The following is a description of a gene set: part of: Metabolism Reactome Pathway: Metabolism of porphyrins Porphyrins are heterocyclic macrocycles, consisting of four pyrrole subunits (tetrapyrrole) linked by four methine (=CH-) bridges. The extensive conjugated porphyrin macrocycle is chromatic and the name itself, <b>porphyrin</b>, is derived from the Greek word for <i>purple</i>. The aromatic character of porphyrins can be seen by NMR spectroscopy.<br>Porphyrins readily combine with metals by coordinating them in the central cavity. Iron (heme) and magnesium (chlorophyll) are two well known examples although zinc, copper, nickel and cobalt form other known metal-containing phorphyrins. A porphyrin which has no metal in the cavity is called a <i>free base</i>.<br>Some iron-containing porphyrins are called hemes (heme-containing proteins or hemoproteins) and these are found extensively in nature ie. hemoglobin. Hemoglobin is quantitatively the most important hemoprotein. The hemoglobin iron is the transfer site of oxygen and carries it in the blood all round the body for cell respiration. Other examples are cytochromes present in mitochondria and endoplasmic reticulum which takes part in electron transfer events, catalase and peroxidase whic protect the body against the oxidant hydrogen peroxide and tryptophan oxygenase which is present in intermediary metabolism. Hemoproteins are synthesized in all mammalian cells and the major sites are erythropoietic tissue and the liver.<p>The processes by which heme is synthesized, transported, and metabolized are a critical part of human iron metabolism; here the core processes of heme biosynthesis and catabolism have been annotated. studied in species Homo sapiens, and this is the list of marker genes: BLVRA, ABCC1, PPOX, HMOX2, COX10, UGT1A4 (NCBI Gene Id 54657), UGT1A1, FABP1, GUSB, SLCO2B1, ABCC2, UROS, SLCO1B1, UROD, ALAS1, BLVRB, SLCO1B3, HMBS, ABCG2, COX15, CPOX, ALAS2, GSTA1 (glutathione S-transferase alpha 1), FLVCR1, FECH, ALB, ALAD, HMOX1